Given this list of marker genes PB2, M, PA, PB1, NA, NS, NP, CALR, CANX, HA, here is a description of the gene set: studied in species Homo sapiens Reactome Pathway: Virus Assembly and Release part of: Influenza Infection Influenza viruses assemble and bud from the apical plasma membrane of polarized cells e.g. lung epithelial cells of the infected host. This asymmetrical process (i.e. apical or basolateral) is thought to have an important role in viral pathogenesis and tissue tropism. In most cases the individual viral envelope proteins are seen to accumulate at the same polar surface from which virus budding occurs, suggesting that they determine the maturation site